The following is a description of a gene set: species: Homo sapiens from publication Chaussabel D, Semnani RT, McDowell MA, Sacks D, Sher A, Nutman TB (PMID 12663451) Monocyte-derived dendritic cells (DC) and macrophages (MΦ) generated in vitro from the same individual blood donors were exposed to five different pathogens, and gene expression profiles were assessed by microarray analysis. Responses to Mycobacterium tuberculosis and to phylogenetically distinct protozoan (Leishmania major, L. donovani, Toxoplasma gondii) and helminth (Brugia malayi) parasites were examined, each of which produces chronic infections in humans yet vary considerably in the nature of the immune responses they trigger. Genes up-regulated in comparison of dendritic cells (DC) exposed to L. major versus DCs exposed to 5 worms/well B. malayi. Human Gene Set: GSE360_L_MAJOR_VS_B_MALAYI_LOW_DOSE_DC_UP, and this is the list of marker genes: PHF1, MSC, TAP1, PPP1R15A, CELF2, CHUK, FBXO9, TNFAIP3, SPINT2, ADSS2, SERPINE2, SEC13, PEX6, STAT4, CD8A (NCBI Gene Id 925), ANKRD12, SCYL3, STOM, TRAF3, RRAGA, SLC22A4, SLURP1, CA3, GBP2, USP11, CLDN8, HSPE1, PIM1, DNAJB1, HHLA1, RAD51, TXN, INHBA, LDAF1, CAND1, PDE1A, SLC5A3, HERC2P3, TRPM1, CLDN4, C22orf31, KIF3A, BNIP3L, GBE1, PPP2CB (protein phosphatase 2 catalytic subunit beta), RABEPK, ENTPD4, IL1B, GPD1, MYL2, CXCR4, CELF3, IFIT1, STX1A, AHSG, SLAMF1, EHD1, GPS2, TPPP, TRPC2, WTAP, CLK1, UGP2, RPS27A, IL6, PSMA4, ALDH1A2, EMID1, DOCK4, PRSS23, PEX11A, ARHGDIA, SLC25A12, SLC2A3, CCL3, HNRNPA3, LOXL1, CD28, UBE2S, FANCI, BTG1, HMGCS2, NFKB1, SUMO3, ABCA4, ATP4B, XBP1, LTK, MAPK9, OLR1, ATP6AP1, RHBDF1, TMED3, PMP22, OLFM4, CRIM1, DENND4A (DENN domain containing 4A), MARCKSL1, TSFM, SLC39A8 (solute carrier family 39 member 8), ICAM1, PLK4, KRT8, GADD45G, MAL, TNIP1, LITAF, PFKL, MT1X, TNFRSF1B, SYN1, NIT1, DPP4, OPLAH, TSC22D4, CALML3, ZFTRAF1, BASP1, SYMPK, PTGFR, AKR1B1 (NCBI Gene Id 231), SRY, ARL4C, BTG3 (NCBI Gene Id 10950, BTG anti-proliferation factor 3), FNDC3A, HGS, PNPLA4, TICAM1, MPP3 (MAGUK p55 scaffold protein 3), APOC3, CTNNB1, KBTBD2, ADRA2A, FAM50B, TOB2, SRD5A1, INSL4, CCP110, ALKBH1 (NCBI Gene Id 8846), SOD2, CFD, NELFB, PTP4A2, ADAM23 (ADAM metallopeptidase domain 23), DIDO1, MBD2, FANCL, TMEM115, SAT1, REG1A, SCFD1, KRT17, CIC, GUCY2F, N4BP1, SRPX, YJU2B (NCBI Gene Id 81576), FOXO3, NINJ1, BLZF1, KLRD1, WNT2B, IL3RA, MLN, PAX8, RPL36A, CRISP1, ZMYM2, CCR7, OGFR, GPR135, PSME2, SF3B3, ASIC3, TRADD (TNFRSF1A associated via death domain), TRAIP, KLRB1, IER3, SELL, USP12, INSIG2, TCHH, CYTH1, PTGIS, SMARCA4, IFITM3, AUH, AGRN, HTRA2 (NCBI Gene Id 27429), CCL8, MMP9, GYS1, EFR3B, ZNF337, SOCS2, PGK1, SLC11A1, SLC6A8, TUBB4A, LRIT1